The following is a description of a gene set: studied in species Homo sapiens Human Gene Set: GSE17721_PAM3CSK4_VS_GADIQUIMOD_1H_BMDC_DN from publication Amit I, Garber M, Chevrier N, Leite AP, Donner Y, Eisenhaure T, Guttman M, Grenier JK, Li W, Zuk O, Schubert LA, Birditt B, Shay T, Goren A, Zhang X, Smith Z, Deering R, McDonald RC, Cabili M, Bernstein BE, Rinn JL, Meissner A, Root DE, Hacohen N, Regev A (PMID 19729616) Genes down-regulated in comparison of dendritic cells (DC) stimulated with Pam3Csk4 (TLR1/2 agonist) at 1 h versus DC cells stimulated with Gardiquimod (TLR7 agonist) at 1 h. mouse primary BMDCs were stimulated with tlr ligands and gene expression changes were profiled on Affymetrix arrays, and this is the list of marker genes: IDH3A, GMFB, HCLS1, ZNF319, VEGFA, TPRKB, PRELP, RAB13, SPRY4, RGS18, TOE1, SERF2, ATP5MF (ATP synthase membrane subunit f), SNX17, DBR1, POLDIP3, CRYBA4, ATL2, HAUS2, MGAT2, SRSF1, TRIM27, THRB (thyroid hormone receptor beta), CMKLR1, ZNG1B, SF3B3, KIF3B (kinesin family member 3B), RAN, GABPA, TPP1, ASCC1, CYP1A2, TMPRSS13, NFS1, PSMA1, PTP4A2, BAG1, YWHAG, ZNF18, TSEN34, MPHOSPH6, CXXC1, USB1, EIF3A, TVP23A, ANP32B, MCM10, DHRS11 (NCBI Gene Id 79154), MRPS23, ZNF146, PCTP, PTCH1, NUDCD2, C1QBP, WDR1, EPHA8, BLM, DECR1, TUG1, HADHB, ZW10, SLC35A5, ORC2, TEFM, ASAH1, ASPA, SYAP1, KLF10, SCEL, TOPORS, TCF25, TMED4, BTK, ANGEL2, ANXA6, EYA4, DIPK2A, RSRC1, TOR4A, YWHAH, LARP1, EEF1E1, PSEN1, CAPRIN1, PPP2R5C, RAP1A, SP3, BUB1, HNRNPUL2, EBPL, TEX15, MRPL9, VSIR, XPO7, RIN2, RNF103, SMC4, GPR65, BPNT1, PTGR2, PJA2, GNG2, CORO1A, ARCN1, NKIRAS1, ELOF1, ATRN, NOP10, CPNE3 (NCBI Gene Id 8895), CNIH1, SNX4, MTFMT, CAMK1, GYG1, TRIM25, DUSP22, ZNF688, SMC3, ARHGAP18 (Rho GTPase activating protein 18), LYPLA2, MED17, TTK, NIPA2, PAX5, TMEM268, CFAP410, CANX, DPAGT1, UFSP2, CBR3, RIOX2, NQO2, STARD8, NIP7, ATP5MG, CDKL2, TMEM229B, ALOX5AP (NCBI Gene Id 241), USP45, GLTP, TRIOBP, PHETA2, KCNMB2, BMP5, MCUB, MRPL50, DLAT, UBE2D2, TCTA, SPC25, ABCB10, JTB (jumping translocation breakpoint), NT5M, ZBED4, TMEM51, CCDC115, ZNF574, TOR1AIP2, UTP18, RPL7L1, DNPEP, USP5, GALC, DBT, NOP16, PRKAG2, PTDSS1, UNC50, CLN3, BMAL1, ZFAND2A, STAG2, RASSF5, FTH1, AAR2, GTF2A1, ACADM, COA5, ASTN2, CA9, PACS2, SLC35A2, BDH1, ATP6V0A2, CFL2, MICOS13, SLC25A47, CTNND1, MIS18A, CCNQ, HSP90B1, MATK, SERAC1, CTSD, CRBN, TAF1D, SEC11A, NAP1L1, VAMP3, TNFSF14